The following is a description of a gene set: Neighborhood of FCGR2B studied in species Homo sapiens Human Gene Set: GCM_FCGR2B Neighborhood of FCGR2B Fc fragment of IgG, low affinity IIb, receptor (CD32) in the GCM expression compendium, and this is the list of marker genes: SIRPB1, RENBP, AANAT, DRG2, CYP2F1, BECN1, EBI3, SUPT4H1, MADD, FCGR2B, GPER1, NEFL (neurofilament light chain), MAPK3, BCAT2, PRKAG1, FEV, PMS2P11, MPP2, DGCR6, CSN3, VPS72, GRM4, AQP7, SLC2A4, IDUA, GSTZ1, PTPN5, PNMT, GCGR, HMGA2, PDE6B, AAMP, FANCC, ZNF8, TLK2, SCNN1G, EOLA1, RABGGTA, AVPR1B